The following is a description of a gene set: Any process that results in a change in state or activity of a cell or an organism (in terms of movement, secretion, enzyme production, gene expression, etc.) as a result of an interleukin-3 stimulus. Human Gene Set: GOBP_RESPONSE_TO_INTERLEUKIN_3 species: Homo sapiens, and this is the list of marker genes: GSK3B, JAK2, SH2B3, GSK3A (NCBI Gene Id 2931), IL3RA, MT2A, CSF2RB